The following is a description of a gene set: Genes predicted to be targets of miRBase v22 microRNA mmu_miR_7650_3p in miRDB v6.0 with MirTarget v4 prediction scores > 80 (high confidence targets). from publication Chen Y, Wang X (PMID 31504780) species: Mus musculus Mouse Gene Set: MIR_7650_3P, and this is the list of marker genes: Prlr, D430041D05Rik, Mosmo, Jag1 (NCBI Gene Id 170642), Clec2h, Kif5b, Dnajc13, Ganc, Tnrc6b, Arhgap15, Ndufs1, Ppp4r3c2, Rbm47, Dlgap1, Atp11c, Atg4a, Pld5 (NCBI Gene Id 319455), Crim1, Stxbp5l, Desi2, Hao2, Dnajc1, Serpinb9f, Fam169a, Iqck, Zbtb41, Ccdc71, Dpy19l2, Phrf1, Ttbk2, Slc9b2, Slc37a3, Zfp157, Garnl3, Atp13a4, Bmpr2, Esm1, Acvr2a, Osbpl8, Pitrm1, Ankrd12, Paip2, Efr3a, Rab23, Fam91a1, B3galt1, Gkn2, Fam107b, Neurod1, Gabrb2, Fam3c, Agbl3, Kmt5a, Dek, Rbms2, Lmbrd1, Sp4, Nucks1, Ppp4r3a, Naaladl2, Atp2b3, Txnl1, Zfp281, Orc3 (origin recognition complex, subunit 3), Acadsb, Trappc9, Slc24a2, Gramd1c, Dclre1b, Zfp704, Kcnh8, Crppa (NCBI Gene Id 75847), Rufy3, Mkx, Atp7a, Rasef, Reps2, Tcf4, Hecw2, Lrriq3, Wdr17, Pclo, Krtap13-21, Hs2st1, Slc25a16, Limd1 (LIM domains containing 1), Ncam2, Snx18, Ppm1b, Atl1, Abcb1a, Olfm3, Git1, Numb, Zfp612, Psapl1, Wapl, Frk, Papola, Yipf4, Egln1, Naa30, Map2k4 (NCBI Gene Id 26398), Themis, Jarid2, Lrrtm2, Slc35d3, Ppp4r2, Stmn2, Hbp1, Dnajc24, Rgs19, Cxxc4, Slc4a10, Milr1, Tceal8, Fsd1l, Chl1, Echdc1, Psme4, Bmp2, Ywhab, Cacul1, Zfp1, Triqk, Glt28d2, Mdm4, Onecut2, Prrx1, Actr3, Lrrc4c, Phactr4, Trpc7, 1700017N19Rik, Aqp4, Cadm4, Pcdhb14, Slc7a10, Rnf145, Cyfip1, Rab10, Uevld, Topors, Wac, Rad17, Thsd7a, Usp34, Rab33a, Srsf7, Dlk1, Abi2, Sox6, Stard3nl, Cysltr1, Prdm16, Rbfox1, Nova1, Mbd4, Trpc5, Kcnj6, Ext1, Scnn1g, Setbp1 (SET binding protein 1)